The following is a description of a gene set: Mouse Gene Set: GOBP_REGULATION_OF_PEPTIDYL_SERINE_PHOSPHORYLATION Any process that modulates the frequency, rate or extent of the phosphorylation of peptidyl-serine. studied in species Mus musculus, and this is the list of marker genes: Cnot9, Pak1, Lats1, Irgm2, Inpp5f, Spry2, Tek, Eif4g1, Ogt, Bdnf (NCBI Gene Id 12064), Bdkrb2, Avp, Gsk3a, Gpd1l, Hgf, Grk2, Akt1, Rack1, Il11, Nck1, Sptbn4, Nrxn1, Irgm1, Tnf, App, Txn1, Hdac6, Akt2, Paqr3, Stox1, Agt, Egfr, Hrc, Braf, Mad2l2, Arrb2, Ntrk3, Bcl2, Ip6k2, Bcar3, Bag4, Rptor, Nos1, Gadd45a, Smyd3, Tfrc, Bak1, Rictor, Tnks1bp1, Epm2a, Il6 (NCBI Gene Id 16193), Ercc6, Mif, Ifnb1, Inpp5k, Akap9, Angpt1, Tenm1, Rassf2, Dkk1, Cav1, Araf, Park7, Lif, Prkaa1, Pdcd10, Phip, Raf1, Stk4, Ucn, Ntf3, Cnksr3, Pten, Ifng, Met, Ntrk2, Ripk2, Crebl2, Dmtn, Mapkap1, Prkd1, Pfn2, Ret, Inpp5j, Isl1 (ISL1 transcription factor, LIM/homeodomain), Igtp, Ppm1f, Dock7, Pink1, Wnt5a, Bax, Oprd1, Smad7, Nsd1, Mlxipl, Wnt3a, Fnip1, Osm, Cd44, Trim6, Fnip2